Given this list of marker genes Adam33, Cst9, Loxl2, Mmp27, Adamts20, Adamts15, Timp3, Mmp24, Serpini2, Tgm7, Ogfod2, Sulf1, Ngly1, Serpina3c, Hyal6, Adamts12, Hyal1, 1810010H24Rik (NCBI Gene Id 69066), F2, Hpse2, Tgm5, Pcsk5, F7, P3h3, Csta3, Mmp12 (NCBI Gene Id 17381), Cst8, Kazald1 (NCBI Gene Id 226156), Adamtsl5, Ctsm, Ctsf, Serpinb2, Loxl3, Serpina3m, Serpinb5, Serpina5, Hyal3, Pappa (pregnancy-associated plasma protein A), Mep1b, BC051665, Serpinb12, Plod1, Serpina11, Serpinb9, Serpina1e, Ctsa, F12, Mmp10, Fam20c, Mmp28, Elane, Hyal4, Serpina3n, Serpinb6d, Ctsd, Serpinf1, Adam4, Mep1a, Adamts10, Egln1, Hrg, Serpinb13 (serine (or cysteine) peptidase inhibitor, clade B (ovalbumin), member 13), Ctsll3, Serpinb10, Mmp17, Ctso, Ctsw, Cst12, Egln2, Mmp25, Hpse, Htra1, Adamtsl3, P4ha2, Cpn2, Prss1, Adam25, Hyal5, Tpbpa, Try4, Itih2, Adam6b, Cela2a, Adamdec1, Serpina1d, Serpinb9g, Serpinb8, Serpine2, Mmp14, Serpina12 (NCBI Gene Id 68054), Adam15, AI182371, Adamts9, Masp2, Adam1a (a disintegrin and metallopeptidase domain 1a), Pamr1, Ctsk, Adamts14, Cstdc1, Pappa2, Plg, Serpinb1b, Ctsj, Ogfod1, Cts6, Itih5, Cst7, Serpina3k (NCBI Gene Id 68438), Adamts13, Ctsh, Serpina9, Serping1, Timp2, Serpinb1a, Serpina1f, Cela1, Adam32, Cstl1, Adam39, Serpinb3b, Tgm1, Mmp19, Ctss, Adam18, Cstdc4, Prss3, Adam30, Mug2, Try10, Ctse, F10, P4ha1, Adam21, Ctsg, Serpini1, Adam34, Serpinb11, Serpinb6b, Tll2, Mmp7, Serpinb9d, Serpina10, Htra4, Mmp2, Serpina1c, Adam24, Serpind1, Serpinc1, Tpbpb, Timp4, Mmp1a, Adamts8, Cela3a, Cst11, Agt, A2ml1, Cstdc2, Prss12, Masp1, Serpinb9f, Plod2, Itih3, P4htm (NCBI Gene Id 74443), Tgm2, F13a1, Adam26a, Loxl4, Adamts6, Serpina7, Egln3 (egl-9 family hypoxia-inducible factor 3), Mmp21, Serpinb3a, Cts3, Loxl1, Adamts1, Tgm4, Try5, Plat, Serpinb9b, Spam1, Serpinb1c, Fam20b, Mmp20, Ctsb, Serpina3f, Cst5, St14, Ctsz, Timp1, P4ha3, Adam10, Mmp15, A2m, Cst3, Adamts4, Lox, Cd109, Adamts2, Adamts16, Pcsk6, Adamts3, Cts7, Ctsq, Serpinf2, Habp2, Serpinb9e, Serpinb6c, Adam5, Ctsc, Serpina3g, Itih1, Serpina6, Adamts19, Stfa1, Kng1, Adamtsl2, Adam1b, Mmp11, Ky (kyphoscoliosis peptidase), Serpina3a, Cstb, Serpine1, Adam3, Cela3b, Adam23, Adam17, Cstdc3, Adam9, Serpina3b (serine (or cysteine) peptidase inhibitor, clade A, member 3B), Adam28 (NCBI Gene Id 57049), Prss3l (serine protease 3 like), Tgm3, Slpi, Adam12, Tgm6, Mmp3, Stfa3, Spinkl, Serpina1b, Csta2, Adam6a, Ambp, Ctsl, Mmp1b, Adamts17, Fam20a, F13b, Plau, Cst6, F9, Serpine3 (NCBI Gene Id 319433), Tll1, Mmp8, Adam7, Stfa2l1, Serpinh1, Prss1l, Adam26b, Cstdc6, Stfa2, Adam22, Hyal2, Serpinb3d, Mmp16, Gm5347, Adam11, Plod3, Adam19 (ADAM metallopeptidase domain 19), Bmp1, P3h2, Htra3, Adamtsl1, Serpinb7, Gm4787, Prss2, Ctsr, Cst13, Adam29, Adam2, Cts8, Gm5409, Mmp23, Astl, Sulf2, P3h1, Adamts5, Mmp13, Cstdc5, Serpinb6a, Serpinb9c, Adamts7, Mmp9, Pzp, Adamtsl4, Serpina1a, Kng2, Serpinb3c, Adamts18, Itih4, Adam20, Tmprss15, Adam8, Csta1, here is a description of the gene set: from publication Naba A, Clauser KR, Hoersch S, Liu H, Carr SA, Hynes RO (PMID 22159717) studied in species Mus musculus Genes encoding enzymes and their regulators involved in the remodeling of the extracellular matrix One hallmark of ECM proteins is their domain-based structure. Exploiting this characteristic, we established a list of diagnostic InterPro domains commonly found in ECM proteins. We know that some of the domains used to select positively for ECM proteins are also found in transmembrane receptors and proteins involved in cell adhesion (growth factor receptors, integrins, etc) that do not belong to the ECM. These families of proteins also display a subset of specific domains and transmembrane domains incompatible with definition as Mouse Gene Set: NABA_ECM_REGULATORS